The following is a description of a gene set: studied in species Homo sapiens Human Gene Set: GOMF_LYSINE_N_METHYLTRANSFERASE_ACTIVITY Catalysis of the transfer of a methyl group from S-adenosyl-L-methionine to the epsilon-amino group of a lysine residue., and this is the list of marker genes: SETD1A, FAM86B1, SMYD3, ETFBKMT, EHMT1, SETD7, WDR5, FAM86B2, SETD9, METTL21A, SETD3, SUV39H1 (SUV39H1 histone lysine methyltransferase), CAMKMT, PRDM8 (PR/SET domain 8), TTLL12, NSD2 (NCBI Gene Id 7468), SETD6, EEF1AKMT3, KMT5C, EEF1AKMT2, EEF2KMT, PRDM9, KMT5A, SETDB2, SETDB1, MECOM, EZH2 (NCBI Gene Id 392834), PRDM6, KMT5B, SETD2, SMYD2, ATPSCKMT, KMT2D, EEF1AKMT4, SETD1B, PRDM16, EHMT2, NSD3, SETD4, METTL21C, EZH1, CSKMT, SETMAR, KMT2A, EEF1AKMT1, SMYD1, NSD1, SMYD5, KMT2B, METTL13, JARID2, DOT1L, N6AMT1, SETD5, KMT2C, ANTKMT, VCPKMT, SUV39H2, PRDM2, ASH1L, PRDM7, SETBP1, METTL22